Given this list of marker genes DACT1, WNT5A, GLI2, HOXA13, IFT172, SHH, HOXD13, GLI3, here is a description of the gene set: The process whose specific outcome is the progression of the hindgut over time, from its formation to the mature structure. The hindgut is part of the alimentary canal that lies posterior to the midgut. Human Gene Set: GOBP_HINDGUT_DEVELOPMENT studied in species Homo sapiens